The following is a description of a gene set: electronically inferred by orthology from the curated human pathway species: Mus musculus This event has been computationally inferred from an event that has been demonstrated in another species.<p>The inference is based on the homology mapping from PANTHER. Briefly, reactions for which all involved PhysicalEntities (in input, output and catalyst) have a mapped orthologue/paralogue (for complexes at least 75% of components must have a mapping) are inferred to the other species. part of: SUMO E3 ligases SUMOylate target proteins Reactome Pathway: SUMOylation of immune response proteins, and this is the list of marker genes: Rela, Sumo1, Pias4, Nfkbia, Nfkb2